The following is a description of a gene set: Abnormal joint physiology studied in species Homo sapiens Human Gene Set: HP_ABNORMAL_JOINT_PHYSIOLOGY, and this is the list of marker genes: PPP3CA, MARS1, NKX3-2, CRIPTO, ADAMTS2, SPTBN1, GON7, ARPC4, PNPT1, DEAF1 (DEAF1 transcription factor), EMG1, OPA1, KIF21A, DLG5, SMOC1, BMPER, GLB1, CAMTA1 (calmodulin binding transcription activator 1), GFM2, COLQ, IRF6, IFITM5, CDK13, WNT7A, SCARF2, MMP2, PMM2, STIM1, ZMIZ1, CHRNE, RAB23, GNPAT, CBL, UFD1, ANAPC1, FUZ, IGHMBP2, NT5C2, IFT74, GJA1, ERBB3, ANKRD55 (NCBI Gene Id 79722), TNNI2, ERCC8, ECE1, PPP2R5D, KDELR2, ABCC8, OTX2 (NCBI Gene Id 5015), SMPD4, NANS, MKKS, CHRND, SEPSECS, CACNA1C, SRPX2 (NCBI Gene Id 27286), MFN2, ABL1, TMEM222, NPR3, COLEC10, WDPCP, LMBRD2, ANO5, ACTB, SHOX, HOXA13, COQ7, HNRNPA1, LRP4 (NCBI Gene Id 4038), P4HA2, TNFRSF11B, SLC6A9, KCNJ11, ZPR1, PRKACB, FILIP1, DPAGT1, COL2A1, GRIA3, MPLKIP, WNT5A, OFD1, HLA-B, SLC25A19, MYH3, BBS10, PHGDH, NOTCH3 (NCBI Gene Id 791), IFT52, HNRNPK (NCBI Gene Id 3190), FLVCR1, CHN1, EXTL3, ASPA, APC2, BLTP1, DYSF, RAD21, ARVCF, F8, CKAP2L, SDHAF1, USP7, DNAJC21, GLRB, PDHA1, SGCA, LZTFL1, FAT4, MATN3 (NCBI Gene Id 4148), CENPE, SERPINH1, EXOC8, HLA-DRB1, GJA8, COL9A2, MVK, ATN1 (NCBI Gene Id 1822), SIN3B, VWA1, KDM3B, MMP13 (NCBI Gene Id 4322), CCDC32, INS, FLRT1, COG3, SHPK, KRT1, PPT1, GPC3, EXOSC5, KMT2B, COMT, DPM1, CHRNA1 (NCBI Gene Id 1134), ITCH, PDPN, RBM8A (RNA binding motif protein 8A), SLC39A14, IFT27, HIRA, TCF12, CRTAP, RERE, GATAD2B, DHODH (NCBI Gene Id 1723), RECQL, DDR2, SLC39A8, NUP188 (nucleoporin 188), PLOD2, PLCH1, LGI4, PROK2, ATP11A, MAMLD1, C1S, ATP7B, PRG4, IDUA, PERP, TNNT3, PAK2, MYPN, PTPN2, BMP4, FGFR1, STING1, RPL26, NF1, SGCG, YRDC, TPM2, MAN2B1 (mannosidase alpha class 2B member 1), MTM1, RAI1, SMAD3, ALDH18A1, FMR1, DNA2, FARSA, FGFR2, ANKLE2, H3-3A, HOXD13, COL25A1, EVC, SCN1A, GLRA1, COQ4, BRCA2, H4C5, GPC4, BRAF, MMP1, ZC4H2, LIMK1, PDGFRB, RFX7, WASF1, NSRP1, TPRKB, BICRA, GDF3 (NCBI Gene Id 9573), FBN1, PIK3R1, HPGD, TRIP13, RFC1, ZEB2 (NCBI Gene Id 9839), AP4E1, LPIN2, EPG5, RUSC2, NPPA, PMS1 (NCBI Gene Id 5378), COG1, COL1A1, FERMT1, GNB2, TBX1, AP4B1, DPH2, BMPR1A, NFKBIL1 (NFKB inhibitor like 1), DCC, DLL1, SMARCA4, RNU7-1, CCDC22, ARFGEF2, ATPAF2, SUFU, DVL3, GRIN1, TWIST1, TFAP2B, GTF2H5, LSS, COL27A1, C19orf12, HNRNPDL, PGM3, TFE3, WDR26, ZNF341, SEMA4A, ECEL1, WDR45B, BAG3 (BAG cochaperone 3), PAX7, CNTNAP1, PPP2R1A, APC, NDUFS3, CHMP1A, FLII, RPL10, RECQL4, CCBE1, SFRP4, HS2ST1, POP1, ZIC1, PMP22, MAP3K7, ALG14, RSPO2, ANKRD17, CHST11, MYH7, TBX15 (T-box transcription factor 15), AHSG, HGD, TBX22, ADGRG1, PCYT1A, EXOC7, SLCO2A1, PQBP1, MAP1B, SCN2A, UBAP2L, FGF17, RAD51, DPYD, CCN6, TRAPPC2, CSGALNACT1, ABHD12, KIF1A (NCBI Gene Id 654843), DNAJB6, GZF1, DEGS1, COL6A1, LIG4, VARS1, PLAA, SMC3, SLC1A2, NOTCH2, GAD1, MSL3, ACTA1, TBCK, PLEC, ATAD1, AHDC1, NTN1, IL1RAPL1, SYT2, SLC4A10, NLRP3, EXOSC8, NUP107, SLC9A6, ITGB4, SGSH, CIITA, C1R, SDHB, BBS9, FIG4, ALG1, NSUN2, KCNAB2, SCLT1, ATP6V1A, PHEX, ZNF469, CPT2, ZMYM2, PLAAT3, ASXL3, OCA2, STAG1, SH3PXD2B, KDM6B, AEBP1, DCHS1 (NCBI Gene Id 8642), MYMK, FLVCR2, TUBA1A, NCAPG2, SPTLC1, DVL1, YWHAG, AP4S1, MED13L, AARS1, GJB1, TOR1A, HSPB1, AP4M1, AMER1, HRAS, CTCF, THOC2, COMP, TET3, EIF4H, IFT122, PTCH2, NACC1, CDC42BPB (CDC42 binding protein kinase beta), CCDC8, PIGL, COLEC11, ASXL1, PRUNE1, IBA57, SKI, SDCCAG8, TYROBP, STXBP1, EXOSC3 (NCBI Gene Id 51010), TGIF1, TANC2 (tetratricopeptide repeat, ankyrin repeat and coiled-coil containing 2), NUP88, DLG4, GORAB, SOX2, CRELD1, AIFM1, ERCC5, TRAF7, SRD5A3, FLNC, VPS53, STIL, SIN3A, SATB1, CAV1 (NCBI Gene Id 857), UCHL1, RTL1, LTBP2, HNF1B, MECOM, SETBP1, PIGS, ADGRL1, MYL1, ADNP, TMEM107, CACNA1E (NCBI Gene Id 777), NFATC2, NPR2, MASP1, PTF1A, ZNF407, REEP1, MED25, PIK3C2A, SLURP1, CEP19 (NCBI Gene Id 84984), COL17A1, HCN1, KMT2D, PRKCZ, FZD2, FUT8 (NCBI Gene Id 2530), KIAA0319L, SCO2, FAM111B, FKTN, GPHN, PLOD1, GNPNAT1, RNF125, ALAD, ITGB6, RRAS, RAB3GAP1, NARS1, SLC1A4, GDF11, GNPTAB, KBTBD13, LMNB2, TBL1XR1, CDC45, COL18A1, IFIH1, CLIP2, CFAP418, GJB2, PSMG2, B3GLCT, SPG11, ENPP1, DUSP6, EMILIN1, KCNJ5, COL6A3, VPS37D, JMJD1C, CLIC2, FGF9, TMTC3 (transmembrane O-mannosyltransferase targeting cadherins 3), FOXH1, NOD2, YY1, XYLT1 (NCBI Gene Id 64131), ALOX12B, COL5A1, PTH1R, HGSNAT, NR4A2, RREB1, BCR, TGM1, SLC25A1, HPDL, ZFX, ARID1B, UBE4B, MAP2K2, EN1, IDH1, PCDH19, TTC8, CEP290, EFEMP2, WDR11, CAPN3, SERPINF1, GNS, LTBP4, ADSS1, SMG9, FGFRL1, FBXL3 (F-box and leucine rich repeat protein 3), CHAMP1, TMEM270 (NCBI Gene Id 135886), PPP2R3C, TENT5A, NAA10, TNRC6B, CAVIN1, DNAJC30, LMNA, PIEZO2, CEP104, TMEM218, MECR (mitochondrial trans-2-enoyl-CoA reductase), TDO2, TOR1AIP1, SRCAP, BRD4, BGN, RNU4ATAC, PSTPIP1, SOX9, NDUFAF4, RET (ret proto-oncogene), SYT1, DRG1, TBR1, VPS37A, POMK, PRDM16, SEC24C, RSPRY1, IMPDH2, COL11A1, SATB2, MLH1, WBP11, TNNT1, KCNH1, MYH2, CUL7, GFPT1, GABRA1, ALS2, IDS, TAF6, ASPH (NCBI Gene Id 56921), SOBP, SIGMAR1, RIPPLY2, CTBP1, PYROXD1, GJB6, RMRP, MORC2, NSD2, SLC12A6, SMAD4, PUM1, KISS1, DHX16, SCAF4, AP1S2, SMARCD1, HSPG2, TBX4, BMP6, SCAPER, WDR35, AFF4, SNUPN, EMD, WIPI2, VAMP1, CLDN11, LAMA5, BMP1, POLR1D, DST, CEP55, GLI1, ATP7A, STAT4, DCPS, STX1A, CTNND2, TP63, RBBP8, EXOC6B, CD96 (CD96 molecule), SF3B4, BCAS3, SLC5A7, NONO, SPRY4, SLC22A4, SHOC2 (SHOC2 leucine rich repeat scaffold protein), EED, SNX14, KIF26A, DLL3, RFC2, ATP6AP1, ESAM, GPT2, ERCC6, DYM, TONSL, EHMT1, NEK9, SCUBE3, STAT3, RRAS2, NRCAM, BRPF1, GPKOW, KLHL41, LMBR1, SHH, RIPK4, MYO18B (myosin XVIIIB), ADAMTSL4, MLXIPL, CLPB, HACD1, POLE, MSH2, HDAC4, TNFRSF1A, GMNN, KIF5A, ALG3, NDRG1, UPF3B, ACADM, CTSK, SMAD2, MESP2, DPF2, TAF4, GTPBP2, PLAGL1, COASY, CPLX1, SETD1A, GTF2IRD2, NIPBL, MYO9A, DYRK1A, MAFB, SPTSSA (serine palmitoyltransferase small subunit A), ELOVL4, HNRNPH2, ADAMTS3, CDT1, LZTR1, TCTN3, IARS2, DBH, OTUD5, GPC6, PIGA, SIK3, NAE1, FARSB, TGFB2, BBS12, VMA21, ATM, FANCI (NCBI Gene Id 751608), EFNB1, CD247, BHLHA9, MAGEL2, SMAD6, RIN2, USP9X, ERCC4, COX11, SOS2, XYLT2, PORCN, ALDH3A2, MYH8, PITX1, TAF1, POLR1A, PEX5, NSD1, PPP1R21 (protein phosphatase 1 regulatory subunit 21), CAMK2A, GDF5, CUL4B, CREBBP, HS6ST1, ALX3, SAMHD1, MAF, IARS1, ALG9, TBX2, MEOX1, MYL2, TGFB1, NLRP1, MET, FIBP, PPP1R12A, GUSB, ANKH (NCBI Gene Id 7995), ERGIC1, EPCAM, CRLF1, PLP1, HNRNPH1, FBXO11, AUTS2, GJA5, FBLN5, EXOSC9, LIFR, ADGRG6, ELN, ITGA7, KISS1R, ASAH1, PHACTR1, CHST14, CHD4, PYCR1, TRPV4, GNPTG, POGZ, SCN9A, MACROH2A1, GCH1, LAGE3, PTHLH, GLI2, ACVR1, SMARCB1 (SWI/SNF related, matrix associated, actin dependent regulator of chromatin, subfamily b, member 1), SLC18A3, CHAT, SCN1B, TLK2, HSPD1, VPS11, FDFT1, CCNQ, SUCLG1, FBLN1, GSC, WFS1, NKX6-2, PSMB8, H4C9, DPM2, ORC4, ATP6V0A2, MUTYH, JAG2, SP7, AIMP1, TGFBR2, ERMARD, PDX1, PRR12, DSE, ALG8, ERLIN2, EPB41L1, RAB18, GDF6, MCTP2, NRAS, ERLIN1, PAX3, PSAT1, SNRPB, GBA1, BRAT1, KLC2, PIGT, TFAP2A, WDR4, NHLH2, HEPHL1, STAC3, P3H1, SIX6, NPHP1, B3GALT6, HBA1, RASA2, GLUL (NCBI Gene Id 2752), SLC35A3, RARS2, P4HB, IHH, ABCC9, DARS2, UBE3A, TRAK1, DOK7, JUP, SLC39A13, CRKL, TMEM70, NOG, LTBP3, ZBTB42, ATRX, COL9A1, DDC, JARID2, STX5, LAMA2, LARGE1, GAS1, RBM28, TBC1D20, IL2RA, KANSL1, PAX2 (NCBI Gene Id 5076), SPARC, ATP6V1E1, TMEM43, AKT1, VRK1 (NCBI Gene Id 7443), COL1A2, ZIC3, LAMB2, PTEN, KCNK9, RYR1, RNF13, PIP5K1C, CFL2, NFIX, LFNG, CYP26B1, ZIC2, POLR3GL, GALNS, SLC2A10, VANGL1, STAG2, NEFL, MPDU1 (mannose-P-dolichol utilization defect 1), PHIP, IFT56, AIMP2, DLK1, ALG2, DDB1, PTRH2, PCGF2, SDHD, AGTPBP1, SCN4A, AMMECR1, PTPN11, CHD3, IQSEC2, CSNK2A1, CTNNB1, SOX11, TNNC2, EVC2, DKK1, WDR19, RIT1, EXOC2, TAPT1, IKBKG, ACTG2, GNAS, ZMPSTE24, MEFV, PPIB, BBS1, LOX, ACBD6, RNF113A, DPYSL5, EZH2, ZNF335, GNB1, TTN, EBP, DHCR24, NFASC (NCBI Gene Id 23114), DNMT3A, COL9A3, EIF5A, WRN, LUZP1, SLC35A2, PDE4D, NXN, TGFBR1, DISP1 (dispatched RND transporter family member 1), COL13A1, LTBP1, MAP3K20 (mitogen-activated protein kinase kinase kinase 20), SMARCAD1, TBCD, NEB, PDXK, PIGP, SMARCA2, RNASEH2B, SYNE2, LONP1, MT-TE, STRADA, TREX1, DONSON, GTF2I, SLC25A46, POMT2, CHRNG, GRIA4, PRRT2, DMD, TBX3, FBXW11, TBX6, KRT9, RAB3GAP2, SPART, DDX3X, ADGRV1 (adhesion G protein-coupled receptor V1), ADAMTSL2, CDH3, TELO2, SIX3, NEPRO, NODAL, TMCO1, ABCD1, PMS2, POLR3A (NCBI Gene Id 11128), SELENON, WDR73, SUZ12, MYBPC1, CHST3, FLNB, KMT2A, SOX10, VAPB, ADAMTS10, COL11A2, DAG1 (NCBI Gene Id 1605), ADAT3, SLC16A2, BBS7 (Bardet-Biedl syndrome 7), TGDS, SF3B2, CNTN1, PNKD, KIF14, REV3L, NSDHL, GCK, RNASEH2A, PTCH1, NADSYN1, ABCA12, PIGN, CLCF1, DDHD2 (DDHD domain containing 2), HBA2, GP1BB, THOC6, CDK10, DHX30, PIGU, SMS, PLK4, CCDC47, NUP85, ZDHHC9, CD244, WNT1, ANKRD11, ALG13, FGF16, TRIP11, GAN (NCBI Gene Id 8139), KY, PGM2L1, KIF22, DSP, COL5A2, KIDINS220, FKBP6, YARS1, BAZ1B, NEDD4L (NCBI Gene Id 93998), UROS, GNE, IL6ST, IL10, LETM1, CDK5, PCNA, PLA2G6, OSGEP, MMP23B, IFT43, FGD1, KDM1A, BBIP1, SPRED2, TP53RK, GTF2IRD1, PROKR2, DYNC2LI1, MEG3, HIKESHI, DNAL4 (NCBI Gene Id 10126), MSTO1, TNXB, GRID2, SOS1, TMEM165, ALOXE3, MAN1B1, TRAIP, MKS1, CLCN3, PIK3CA, ADAMTS17, BBS5, FOCAD, ARF1, CCN2, ABCC6, ATR, CDH11, VPS33B (NCBI Gene Id 55513), CCR6, TUBB3, H1-4, SMC1A, PCNT, CHRNB1, KRT14, LAMB3, KRT16, OCRL, FUS, AP1G1, NCF1, BIN1, FBXO28, IFT172, ASPN, GLI3 (NCBI Gene Id 2737), CAMLG, KIF5C, GTF2E2, POMT1, PRKACA, ARSB, LMOD3, ASH1L, GARS1, KCNJ6, GBE1, BICD2, FUCA1, PPP1CB, FKBP10, STX1B, CANT1, PEX1, DPH1, FITM2, GNAI3, PHF6, SHANK3, TOGARAM1, SCN5A, HDAC8, CDON, NGLY1, HERC1, UNC80, SPEG, ORAI1, PTDSS1, HINT1, INF2, LMNB1, BBS2, KDM5B, B3GAT3, INPPL1, TACR3, GDAP1, TRPV3, BCL11A, CHEK2, MYOD1, MAPK1, SPEN, MICU1, TBL2, RPS20, SVIL, PSMB4, GABRG2, TPM3, CRPPA, TAC3, COG8, IGF2, PPP1R15B, PTPN22 (protein tyrosine phosphatase non-receptor type 22), ADAR, TARS1, TBC1D2B (TBC1 domain family member 2B), FN1, RPS6KA3, ANTXR1, PEX2, PUS1, SEMA5A, GABRD, IDH2, RAP1B, DCX, FHL1, ACADS, ATP5F1D, SLC6A5, ARID2, SEC24D (SEC24 homolog D, COPII coat complex component), ZNHIT3 (zinc finger HIT-type containing 3), NIPA1, RFT1, RNU12, MSH6, LMX1B, SLC10A7, SET, TRIM2, BPNT2, RAF1 (NCBI Gene Id 5894), TWIST2, GNRH1, CDC42 (cell division cycle 42), GNRHR, TRIP4, ESCO2, OTUD6B, SUMF1, PEX6, MED12, IPO8, MTMR14, SMARCE1, ATP2A1, PI4KA, ACAN, HUWE1, NSMF, GMPPB, FOXP1, MECP2, RIC1, IL2RB, HNRNPA2B1, ASXL2, FGF8 (fibroblast growth factor 8), FLNA, ATP6V1B2, SPRTN, BMPR1B, LIAS, FAM20C, KIF15, SMARCC2, CTDP1, PUF60, MTRFR, EIF4A3 (NCBI Gene Id 9775), RTTN, CEP152, RAPSN, MYL11, SEC23A (SEC23 homolog A, COPII coat complex component), ZMYM3, MBTPS2, FCSK, GLDN, HOXA11, RAP1GDS1, COG5, CADM3, PIK3R2, BANF1, SLC26A2, USB1, EXT1, KAT6B (lysine acetyltransferase 6B), SDHA, ORC6, KRAS, TRMT10A, MTX2, KLHL7, RAC1, SIL1, MEGF10, TRIM32, ADCY6, MED11, ARCN1, SLC6A8, KIAA0753, SEC31A, SPTAN1, SLC25A4, PLEKHG5, POR, ADAMTS15, FGFR3, VIPAS39, B4GALT7, CDC6, PYCR2, FGF13, LBR, HFE, FBN2, ERCC1, IRF5, CASZ1, ANTXR2, SCYL2, HEXB, VPS13B, GOLGA2, SLC29A3, EFEMP1, CBS, ROR2, PRDM5, CHSY1, EXT2, METTL27, NDE1, MUSK, P4HTM, FERRY3, PKDCC, RBMX, UBA1, PIGG, SON, SALL1, AGA, C18orf32, SALL4, COL3A1, KCNN3, AGRN, SLC35B2, ERI1, ZBTB20, NKAP, PIGY, CARS1, FKRP, ASCC1, ERCC3, SOX4, MEGF8, ALG12, FKBP14, ORC1 (NCBI Gene Id 4998), DDRGK1, TREM2, KRT83, LEMD3 (NCBI Gene Id 23592), THBS2, KDM5C, ARL6, BUD23, CISD2, H3-3B, MRAS, SNAP25, HK1, COL12A1, FANCC, KLHL40, NAGLU, TRIM8, HYAL1, CREB3L1, MRE11, RAB33B, TAOK1 (NCBI Gene Id 80214), MYOT, TSEN54, UFC1, NALCN, CACNA1A, MMP9, MRPS34, ARX, IL1RN, HYMAI, TBX5, RYR3, PLOD3, RNASEH2C (ribonuclease H2 subunit C), COL7A1, BBS4, KCNJ2, GLE1, ACTG1, LRP5, B9D2, SPTBN4, SOX5, VCP, NUP133, KLHL9, ALX1, DNM2, ARID1A, UBR1, PLXND1, ATRIP, EP300, CHD7, OPA3, BCOR, BRF1, TGFB3, SYNE1, ACER3, KDM6A, LSM11, COL6A2, PEX7, OBSL1, VPS33A, POLD1, TNPO3, L1CAM, TRPS1, ERCC2, HES7